The following is a description of a gene set: species: Homo sapiens Any process that modulates the frequency, rate, or extent of an acute inflammatory response. Human Gene Set: GOBP_REGULATION_OF_ACUTE_INFLAMMATORY_RESPONSE, and this is the list of marker genes: APCS, FUT7, EDNRB, NLRP3, C2CD4B (NCBI Gene Id 388125), DNASE1L3, KLKB1, IL6ST, MIR92A1, OSMR, TNFSF11, C2CD4A, ASH1L, TNF, ADORA1, DNASE1, CCR7, TAC1, GSTP1, TNFRSF11A (TNF receptor superfamily member 11a), F12, PIK3CG (phosphatidylinositol-4,5-bisphosphate 3-kinase catalytic subunit gamma), FFAR2, NPY5R, PLA2G2D, C3, HLA-E, FFAR3, INS, CREB3L3, OSM, IL20RB, SELENOS, PTGES, PTGER3, IL1B, FCGR2B, PTGS2, FCER1G, IL6, FCGR1A, BTK, SPN, PARK7, MIR302E, RHBDD3, ADAM8, ZP3, NPY